Given this list of marker genes Rgs4, Gsk3b, Pparg, Tnfrsf1a, Fbxo32, Tomm70a, P2rx4, Igfbp5 (insulin-like growth factor binding protein 5), Pak1, Ppara, Smad3, Mstn, G6pd2, Rgs2, Bmp10, G6pdx, Rbm10, Akap1, Lmna, Ctdp1, Trim63, Cav3, Gsk3a, Atp2b4, Foxo1, Errfi1, Notch1, Smad4, Jarid2, Pi16, Kcnn4, Zfp418, Tnfrsf1b, Yy1, Glrx3, Gdf1, Gata5, Stub1, Foxp1, Mlip, here is a description of the gene set: species: Mus musculus Any process that stops, prevents, or reduces the frequency, rate, or extent of muscle hypertrophy. Mouse Gene Set: GOBP_NEGATIVE_REGULATION_OF_MUSCLE_HYPERTROPHY